The following is a description of a gene set: Binding to protein phosphatase 2A. species: Homo sapiens Human Gene Set: GOMF_PROTEIN_PHOSPHATASE_2A_BINDING, and this is the list of marker genes: PPP2R2A, IGBP1, ADCY8 (adenylate cyclase 8), SMG5, SPHK1, STAT1, ENSA, SMG7, STRN4, MFHAS1, GRIN3A, STRN, CTTNBP2NL, MAPT, MASTL, SLC6A3, PPME1, DAB2IP, BCL2 (NCBI Gene Id 596), ARPP19, PTPN1, BOD1 (biorientation of chromosomes in cell division 1), ANKLE2, PABIR1, PTPA, IGBP1C, TP53, STRN3, FOXO1, GNA12